Given this list of marker genes Prkar1a, Trp53, Nf1, Mmp8, Cdkn2a, Mif, Kras, Dkc1, Nf2 (NCBI Gene Id 18016), Prdx1, S100a4, Fosl2, Bub1b, here is a description of the gene set: species: Mus musculus Mouse Gene Set: MP_INCREASED_FIBROSARCOMA_INCIDENCE Mouse genes annotated to increased fibrosarcoma incidence (MP:0010363) retrieved from the Mouse Genome Informatics database via MouseMine from publication Motenko H, Neuhauser SB, O'Keefe M, Richardson JE (PMID 26092688)